The following is a description of a gene set: studied in species Mus musculus Genes with promoters bound by FOXP3 and which are down-regulated only in developing (located in the thymus) regulatory CD4+ T lymphocytes. Mouse Gene Set: ZHENG_FOXP3_TARGETS_IN_THYMUS_DN from publication Zheng Y, Josefowicz SZ, Kas A, Chu TT, Gavin MA, Rudensky AY (PMID 17237761) Transcription factor Foxp3 (forkhead box P3), restricted in its expression to a specialized regulatory CD4+ T-cell subset (T(R)) with a dedicated suppressor function, controls T(R) lineage development. In humans and mice, Foxp3 deficiency results in a paucity of T(R) cells and a fatal breach in immunological tolerance, causing highly aggressive multi-organ autoimmune pathology. Here, through genome-wide analysis combining chromatin immunoprecipitation with mouse genome tiling array profiling, we identify Foxp3 binding regions for approximately genes and for an intergenically encoded microRNA. We find that a large number of Foxp3-bound genes are up- or downregulated in Foxp3+ T cells, suggesting that Foxp3 acts as both a transcriptional activator and repressor. Foxp3-mediated regulation unique to the thymus affects, among others, genes encoding nuclear factors that control gene expression and chromatin remodelling. In contrast, Foxp3 target genes shared by the thymic and peripheral T(R) cells encode primarily plasma membrane proteins, as well as cell signalling proteins. Together, our studies suggest that distinct transcriptional sub-programmes implemented by Foxp3 establish T(R) lineage during differentiation and its proliferative and functional competence in the periphery., and this is the list of marker genes: Adipoq, Agr2, Akr1d1, Tube1, Nr4a2, Epb41, Trim12a, Gm26680, Amph, Prss2, Aph1a, Zbed3, Map4k4, Cadps